The following is a description of a gene set: Genes bearing the H3K27me3 mark in normal cells; their DNA is methylated in cancer cells. Human Gene Set: SCHLESINGER_H3K27ME3_IN_NORMAL_AND_METHYLATED_IN_CANCER Many genes associated with CpG islands undergo de novo methylation in cancer. Studies have suggested that the pattern of this modification may be partially determined by an instructive mechanism that recognizes specifically marked regions of the genome. Using chromatin immunoprecipitation analysis, here we show that genes methylated in cancer cells are specifically packaged with nucleosomes containing histone H3 trimethylated on Lys27. This chromatin mark is established on these unmethylated CpG island genes early in development and then maintained in differentiated cell types by the presence of an EZH2-containing Polycomb complex. In cancer cells, as opposed to normal cells, the presence of this complex brings about the recruitment of DNA methyl transferases, leading to de novo methylation. These results suggest that tumor-specific targeting of de novo methylation is pre-programmed by an established epigenetic system that normally has a role in marking embryonic genes for repression. species: Homo sapiens from publication Schlesinger Y, Straussman R, Keshet I, Farkash S, Hecht M, Zimmerman J, Eden E, Yakhini Z, Ben-Shushan E, Reubinoff BE, Bergman Y, Simon I, Cedar H (PMID 17200670), and this is the list of marker genes: HOXA9 (homeobox A9), GAD2, HOXD12, PCDHAC1, AMPH, KCNA1, TRHDE, COL1A1, SOCS1, PCDHGB5, FAM110A, SFRP4, GNAL, GRIA4, HTR1A (5-hydroxytryptamine receptor 1A), GJD2, POU4F3, HBA2, GRM7, GDF10, AQP5, DES, HS3ST2, CRHR2, GRM6, NEUROG3, MYT1, GPR6